The following is a description of a gene set: Human Gene Set: HP_ANTERIORLY_PLACED_ANUS Anterior malposition of the anus. Anteriorly placed anus species: Homo sapiens, and this is the list of marker genes: RECQL4, CDC45, GLI2, SALL1, ATN1, DACT1, DDX3X, FGFR2, RRAS2, CRIPTO, CDH11, C2CD3, KYNU, TWIST2, ESCO2, FREM1, FAT4 (FAT atypical cadherin 4), POR, DDB1, KAT6B, GLI3, PIGW, ZIC2, ERCC4, LRPPRC, ROBO1, CDK8, SNRPB, DDX6, PGAP3, FGF8, TGIF1, DISP1, HCCS, DLL1, NIPBL, NFIX, CHD4 (NCBI Gene Id 1108), B3GLCT, FOXH1, RFX6, PIGO, SLC25A24, DVL3, DCHS1, PIGV, NDUFB11, UBR1, CDON, PORCN, PGAP2, MAB21L1, SHH, SUZ12, SIX3, STIL, KMT2D, KDM6A, ACADVL, SETBP1, PIGY, MED12, TP63, GAS1, PIGL, PTCH1, PTDSS1, NODAL, COX7B